The following is a description of a gene set: Human Gene Set: HP_ABNORMAL_DARK_ADAPTED_BRIGHT_FLASH_ELECTRORETINOGRAM studied in species Homo sapiens Abnormal dark-adapted bright flash electroretinogram, and this is the list of marker genes: GRK1, SLC24A1, GPR179, SAG, GNB3, LRIT3, RHO (NCBI Gene Id 6010), RS1, PDE6B, GNAT1, TRPM1, CACNA2D4, RLBP1, GRM6, NYX, CFAP418, CABP4, ABCA4, CACNA1F